The following is a description of a gene set: Human Gene Set: GOBP_SKIN_DEVELOPMENT The process whose specific outcome is the progression of the skin over time, from its formation to the mature structure. The skin is the external membranous integument of an animal. In vertebrates the skin generally consists of two layers, an outer nonsensitive and nonvascular epidermis (cuticle or skarfskin) composed of cells which are constantly growing and multiplying in the deeper, and being thrown off in the superficial layers, as well as an inner vascular dermis (cutis, corium or true skin) composed mostly of connective tissue. studied in species Homo sapiens, and this is the list of marker genes: PKD1, ATP7A, PKP1, STMN1, HOXC13, KRT7 (NCBI Gene Id 3855), PLEC, OVOL2, KRT77, CLDN1, ITGA3, SPRR5, FOXI3, TCHH, NSDHL, TSG101, TGM1 (transglutaminase 1), IVL, MAFB, KRT75, CSTA, NAGLU, NUMA1 (nuclear mitotic apparatus protein 1), ZFP36, PAX6, PLAAT4, RYR1, NME2, LCE1B, IFT74, KPRP, SRF, COL5A2, LCE6A, WNT10A, REG3A, SPRR4, CYSRT1, DKK1, TNFRSF19, FAM210B (family with sequence similarity 210 member B), IRF6, MYD88, GRHL1, TGM3, HRNR, STK4, CYP27B1, ABCA12, SOX21, KLK5, LCE1C, ETV4, IGFBP5, VDR, LCE2D, TRAF3IP2, SPRR3, IL17A, CNFN (NCBI Gene Id 84518), KRT36, NOTCH1 (notch receptor 1), YAP1, KRT1, HOXA7, FLG, EZH2, FOSL2, LDB2, LIPM, PPHLN1, DLL1, KRT84, KRT9, POU3F1, BCL2, CASP3, ACER1, ERRFI1, PDGFA, AKR1C3 (NCBI Gene Id 96424), APCDD1, ARRDC3, PLA2G10, PPP3CA, OVOL1, GAL, LCE1A, MACROH2A2, KRT85, ADAMTS2, KRT3, VANGL2, UGCG, FA2H, SLC27A4 (NCBI Gene Id 9176), SPRR2F, KRTAP6-1, CDKN2A, OPN3, LTB, LGR4, SLC39A2, COL6A1, SRSF6, DHCR24, LCE3A, KRT83, TMEM79, ZFP36L1, MSX2, FGF10, PALLD, DSC1, TXNIP, KRT80, DKK4 (NCBI Gene Id 27121), SOX18, ITGA6, BCR, KRT74, TFAP2C, ANXA1, EXPH5, ITGA2, COMP, CD109, KRT76, KRT27, SHARPIN, KRT14, LAMA5, STARD7, LIPN, ALOXE3, ELOVL1, ASH1L, CASP14, FST, TNF, KRT81, ST14, SNAI1, KRT6B, COL5A1, LATS2, LCE3E, SUFU, LCE3C, COL1A1, CDSN, LHX2, EXTL3, SFN, LIPK, ALOX12B, KDF1, LDB1, KRT6C, KRT72, CLIC4, FOXQ1, SAV1, PPL, KRT28, EGFR, KRT4, CDKN1A, IL20, ZMPSTE24, KRT25, KRT17, SPRR2D, MIR125B1, LORICRIN, KRT2, DACT2, KRT79, LCE2A, SOSTDC1 (sclerostin domain containing 1), PIP5K1A, MED1, MYSM1, HPSE, GLI2, LCE1F, PKP3, EREG, FLG2, LGR5, SPRR1B, DSP, RELA, SLITRK5, AP3B1, WNT16, JAG1, FZD3, FOXN1, VPS33B, GATA6, KRT5, CTNNB1, LCE2C, COL3A1, ASCL4, TP63, NFKBIZ, EPHA2, ADAM9, KRT82, LCE3D, SHH, RBPJ, LRP4, FZD6 (NCBI Gene Id 8323), TNFSF13B, ASPRV1, DNASE1L2, TMPRSS11F, INTU, KRT73, INHBA, LATS1, FLNB, GNAS, LCE1E, PSEN1, LCE2B, KRT86, NSUN2, FUZ, PUM2, SPRR2B, ROCK1, ASAH1, ATP8A2, BCL11B, TRADD, FRAS1, ERCC2, S100A7, SCEL (sciellin), JUP, GRHL3, HDAC2, KRT6A, EDAR (ectodysplasin A receptor), NF1, SPRR2G, DLX3, FGFR2, AQP3, FGF7, KRTAP6-2, DSG4, ITGB6, WNT10B, TGFB2, TRPC4AP, MET, KRT16, SPRR1A, KRTAP6-3 (NCBI Gene Id 337968), SGPP1, CERS3, NGFR, NCOA3, REG3G, LCE3B, FOXC1, SOX9 (SRY-box transcription factor 9), KRT71, KLF4, ACVR1B, RIPK4, ALX4, FERMT1, LCE1D, TRIM16, TFAP2B, KAZN, GORAB, PRKCH (protein kinase C eta), ZNF750, EDA, SPINK5, EVPL, LSR, POU2F3, CDH3, ZBED2, KRT78, LCE5A, CLDN4, LCE4A, AHDC1, FOXE1, SOS1, ROCK2 (Rho associated coiled-coil containing protein kinase 2), COL5A3, PTCH2, CYP26B1, IL18, MAP2K1, EXT1, SMO, HDAC1, MACROH2A1, WDR48, HDAC3, SPRR2E, GRHL2, SMAD4, WNT5A, SLC39A7, COL1A2, ALOX15B, ITGB4, KRT10, ALOX12, GBA1, PIAS4, ZDHHC21, SLC2A10, NOM1, LCE7A, ABCB6